Given this list of marker genes LHX1, NTN1, UNC5C, LHX9, DCC, UNC5B, UNC5A, here is a description of the gene set: The process in which the migration of an axon growth cone is directed to a specific target site along the anterior-posterior body axis in response to a combination of attractive and repulsive cues. The anterior-posterior axis is defined by a line that runs from the head or mouth of an organism to the tail or opposite end of the organism. species: Homo sapiens Human Gene Set: GOBP_ANTERIOR_POSTERIOR_AXON_GUIDANCE